Given this list of marker genes GRIP1, EP300, POLR1D, CREBBP, PAX1, YY1, MEGF8, FRAS1, FGF10, IGSF3, FREM2, PPP1CB, TCOF1, CD151, SOX6, NHP2, SMC5, CTLA4, TET3, SMCHD1, PTPN22, TGDS, POLR1C, PAX3, KMT2D, PRTN3, TFAP2A, NDUFB11, TAF1, SF3B4, PRR12, PIK3CD (phosphatidylinositol-4,5-bisphosphate 3-kinase catalytic subunit delta, NCBI Gene Id 5293), HMX1, COL3A1, FGFR3, HLA-DPB1, EYA1, NOP10, SPRED2, FOXL2, KAT6A, TP63 (tumor protein p63), FREM1, NIPBL, PTDSS1, SMC3, KDM6A, TRRAP, POLR1B, KNSTRN, TWIST1, HLA-DPA1, MED12, SIX5, USB1, SIX1, FGFR2, here is a description of the gene set: studied in species Homo sapiens An abnormality of the lacrimal duct, a duct that drain tears from the conjunctiva, via the lacrimal puncta, into the lacrimal sac. Abnormal lacrimal duct morphology Human Gene Set: HP_ABNORMAL_LACRIMAL_DUCT_MORPHOLOGY